The following is a description of a gene set: species: Homo sapiens Human Gene Set: KEGG_MEDICUS_VARIANT_AMPLIFIED_CDK4_TO_CELL_CYCLE_G1_S Amplified CDK4 to cell cycle G1/S. Pathway ID: N00072. Pathway type: Variant. Pathway class: nt06273 Glioma. Pathway Definition from KEGG: (CCND+CDK4*) -> RB1 // E2F, and this is the list of marker genes: E2F2, E2F1, RB1, CCND1, CCND3, CCND2, CDK4, E2F3